Given this list of marker genes NDST3, TNFSF9, ALPK3, ZSWIM6, CREB3L3, PIKFYVE, NFATC4, KIAA1549, LZTS3, CPLX3, COLQ, HIVEP2 (NCBI Gene Id 3097), JPT1, MAGI1, HLA-DOB, MFSD14A, MAP2, MCTP1, NDOR1, RHOBTB1, CDK9, WFS1, MED8, TGFBR3, BSDC1 (NCBI Gene Id 55108), TWNK, IGBP1, STRN, RETREG1, TNR, REV1, HOXA5, XPO4 (NCBI Gene Id 64328), PKNOX1, ZMIZ1, ANAPC7, HNRNPR, PTGER4, CARHSP1 (NCBI Gene Id 23589), SOX5, JADE2, RAB30 (NCBI Gene Id 27314), DAG1, PDGFA, SLC20A2, ADGRE2, MYCBP2, HK2, DPYSL2, AVL9, ACVR1B, PTPRE, QTRT2, TBCD, CSF1, CRTC3, TSGA10, TNRC6C, ABCB10, SERTAD1, TGM2, CYB5B, IFNAR1, EFNA5, EFR3B, CSRNP2, DCBLD2, SNN, VKORC1, TOR3A, SPDYA, MGAT5, BTG4, HIPK1, KCNJ14, EPX, FGF1, here is a description of the gene set: studied in species Homo sapiens from publication Chen Y, Wang X (PMID 31504780) Human Gene Set: MIR3155A_MIR3155B Genes predicted to be targets of miRBase v22 microRNA hsa-miR-3155a, hsa-miR-3155b in miRDB v6.0 with MirTarget v4 prediction scores > 80 (high confidence targets).